Given this list of marker genes ISCU (NCBI Gene Id 91850), NDUFA13, GRPEL1, MAEA, PTPN2, URI1, ITGB8, CFP, SIPA1L1, EVX2, HIVEP2, PLA2G12A, PXT1, GTF3C4, SOAT2, NAA25, MTERF3, LIMK1, ATF4, GALNT7, EXO5, CD320, CHAC1, ABCD3, ESD, DGKG, ARL15, GPD1, GHITM, SEL1L3, PHGDH, ALK, SNHG12, PLOD3, TMED5, NADSYN1, PPP1R21, CAPZB, HOXA7, OIT3, POU3F4, LTA4H, THRA, CDH17, PLVAP, USP18, SDE2, NAPEPLD, ZNF532, SNHG6, LMO4, DUSP4, SLC7A1, MYRF, FOXH1, LAT, IER3 (NCBI Gene Id 91950), CREB3L2 (cAMP responsive element binding protein 3 like 2), ALG5, RNF32, DHRS11, CYBA, CD36, CLCNKA, RNF113A (NCBI Gene Id 7737), FGFR4, HILPDA (NCBI Gene Id 92496), ATP6V1E1, ALKBH1, TDRD3, EIF3K, NDUFS7, KCNK4, CSDE1, MOCS2, HOXD1, RILP, CCDC59, SHISA9, ADHFE1, NT5DC3, PDIA4, EIF3D, HSPA1B, SSB, DDRGK1, SHISA2, STS, GORASP2, TRMT61A, COQ9, ARHGAP12, COX18, EPRS1, EEF1B2, GALNT15, DNAJA3, LMAN2, SERTAD2, SHQ1, FBXO32, E4F1, COX11, UBXN1, OLFM1, PFDN2, NCK1, CKAP4, TOM1L1, ATP6V1B2, SEPTIN9, TCERG1L, CHP1, JUN, PKDCC, HCN3, NEURL2, UBAC2, MN1, LARS1, C19orf44, LEO1, HNRNPH3, MRPS28, NIPA2, YAE1, PRPF38B, EIF2B2, TCEAL7, DUSP1, EARS2, ARIH1, RGS1, AKIRIN2, RASSF8, GALNT6, CASP6, FAM227A, NUDT9, MCTS1, MRPS26, GCNT1, KLF10, RSL1D1, RAMP3, PTPN3, N4BP1, GLA, NT5M, RUNX2, CKB, ENPP6, RTF2, RPS9, OSGEP, APTX, ERP44, CLIC4, C11orf58, TTPAL, TMEM165, DDX54, MIR99AHG, HSPA1L, IGSF3, CERS6, ELL2, LAYN, ZC3H12A, ADGRG5, SYDE2, RETSAT, AVIL, LONP1, SLC36A2, EGR4, GTPBP2, AHCYL1, ATMIN, COMTD1, TMEM181 (NCBI Gene Id 57583), RITA1, MAP4K1, NFE2L1, TMEM205, TMEM179B, SEL1L, UBE2E1 (ubiquitin conjugating enzyme E2 E1), ZNF706, RXYLT1, SPIRE1, SOCS2, ARL6IP5, TSPAN31, TRIM36, STAB2, RARG, BTBD3 (NCBI Gene Id 22903), METRNL, here is a description of the gene set: studied in species Homo sapiens Genes down-regulated in bone marrow-derived macrophages at 45 min of stimulation by LPS: IL6 knockout versus IL10 knockout. IL-10 or IL-6 stimulation of control 129xC57BL/6 murine bone marrow derived macrophages in the presence of LPS. We used microarrays to detail the global programme of gene expression changes in response to IL-6 or IL-10 stimulation in the presence of lipopolysaccharide. BMDMs were isolated from control, IL-6-/-, and IL-10-/- mice on a 129XBL/6 mixed background mice and differentiated in the presence of CSF-1 for 6-7 days. Cells were scraped and plated in 6 well plates at 2x10e6/well. Cells were washed with complete DMEM and rested for 1-2 hr before stimulation with combinations of IL-10 (10 ng/ml), IL-6 (2 ng/ml) or LPS (100 ng/ml) for 45 min or 180 mins. Complete biological replicates were performed. from publication El Kasmi KC, Holst J, Coffre M, Mielke L, de Pauw A, Lhocine N, Smith AM, Rutschman R, Kaushal D, Shen Y, Suda T, Donnelly RP, Myers MG Jr, Alexander W, Vignali DA, Watowich SS, Ernst M, Hilton DJ, Murray PJ (PMID 17114459) Human Gene Set: GSE5589_IL6_KO_VS_IL10_KO_LPS_STIM_MACROPHAGE_45MIN_DN